Given this list of marker genes CDH6, CDH1, VIM, RUNX2, CDH16, MAPK1, AKT3, SMAD4, AKT1, SNAI1 (NCBI Gene Id 6615), FN1, AKT2, MAPK3, SNAI2, CDH2 (cadherin 2), SMAD2, TNC, ID1, SMAD3, here is a description of the gene set: Human Gene Set: WP_TGFBETA_SIGNALING_IN_THYROID_CELLS_FOR_EPITHELIALMESENCHYMAL_TRANSITION studied in species Homo sapiens TGF-beta signaling in thyroid cells for epithelial-mesenchymal transition